The following is a description of a gene set: Human Gene Set: GOBP_GRANZYME_MEDIATED_PROGRAMMED_CELL_DEATH_SIGNALING_PATHWAY species: Homo sapiens The series of molecular signals induced by granzymes which triggers the cell death of a cell. The pathway starts with reception of a granzyme signal, and ends when the execution phase of cell death is triggered. Granzymes are serine proteases that are secreted by cytotoxic T cells and natural killer cells to induce cell death in target cells., and this is the list of marker genes: GZMA, SRGN, PRF1, GZMK, GZMB, GSDME, UBE4B, NKG7, GSDMB, BNIP3, LAMP1